The following is a description of a gene set: Reactome Pathway: Suppression of apoptosis In order to survive and grow within the phagocyte, Mtb has to inhibit programmed cell death. Several proteins are secreted by Mtb that block different pathways leading to complete arrest of apoptosis (Moraco & Kornfeld 2014). studied in species Homo sapiens part of: Response of Mtb to phagocytosis, and this is the list of marker genes: CTSG, MAPK1, GSK3A, ptpA, RNF213, MAPK3, Rv3364c, Rv3654c, TRIM27, Rv3655c, lprM, SFPQ